Given this list of marker genes EDEM3, PAQR9, CD163, ARID2, NABP1, GSKIP, RAP2A, ASPN, CHIT1, SEPTIN7, SRP9, ELOVL5, OTUD1, ZSCAN5A, RPRD1A, RAP1A, FNIP1, HMGXB4, ZKSCAN5, GUCY1A2, SSR3, EIF5B, ZNF547, PEAK1, NECTIN3, ABCC4, GTF3C4, DYRK2, DZIP1, FBRSL1, GLRA2, SNX4, MAPK1, PUM2, AGO2, CDS1, RPRD2, KLF3, MYO3B, IGF2BP1, RNF103, NUAK1, NOTCH2, CAST (calpastatin), SGK1, TACC2, ZNF516, AKAP6, SUB1, WNK3, TET3, TGIF2, NPPA, EFHC2, WWC1, SRSF6, COX7A2L, ZNF106 (zinc finger protein 106), INO80D, C1QTNF7, ZNF827, MEF2C, LY6K, IST1, ACSS3, SGIP1, BCL7A, RPS6KA6 (NCBI Gene Id 27330), PBX1, PAK1, MAPK6, KPNA4, DCUN1D1, FRS2, RBM15B, CSE1L, NR3C2 (nuclear receptor subfamily 3 group C member 2), LCOR, ROR2, INSM1, TSPAN9, FGF1, SEL1L (NCBI Gene Id 6400), CALU, ZBTB14, SOCS5, MINK1, ASZ1, SDE2, UBE2D2, FBXW7, RAB10, ZNF454, MRPL44, BBX, MEX3C, KCTD9, SLC35A2, MORC2, PLEKHF2, MICAL2, TMEM181, STK38L, PLSCR5 (phospholipid scramblase family member 5), CCN2, GIGYF2, ETF1, SPHKAP, ZNF214, CA13, SLC35D1 (NCBI Gene Id 23169), CRTAP (NCBI Gene Id 253263), ARID4A, AKIRIN1, BPGM, DPYSL5 (dihydropyrimidinase like 5), NPTN, WDFY3, NRAS, SIRT5, CUL4A (NCBI Gene Id 8451), EPB41L5, SLC35F1, PRRC2C, UBE2B, PFKFB3, AMD1, FUBP1, PRDM1, TDRP, NCBP1, YIPF4, ZIC2, SASS6, CDYL2, FBXO4, TCHHL1, TRMT2B, NR4A3, TRMT9B, CLDN5 (NCBI Gene Id 7122), SNAP25, FGF13, PDIK1L, ELK3, SULF2, ZC3H12B, EREG, CTDSP2, ATM, SLC35A3, UBR5, NBPF3, EIF3A, RAB29, TTC14, AGGF1, FOXO1, SYBU, FNBP1, CNTNAP3B, CFAP263, ZMIZ1, GRIA3, here is a description of the gene set: species: Homo sapiens Human Gene Set: MIR6715A_3P from publication Chen Y, Wang X (PMID 31504780) Genes predicted to be targets of miRBase v22 microRNA hsa-miR-6715a-3p in miRDB v6.0 with MirTarget v4 prediction scores > 80 (high confidence targets).